The following is a description of a gene set: Human Gene Set: GOCC_COLLAGEN_TYPE_IV_TRIMER A collagen heterotrimer containing type IV alpha chains;2alpha2(IV) trimers are commonly observed, although more type IV alpha chains exist and may be present in type IV trimers; type IV collagen triple helices associate to form 3 dimensional nets within basement membranes. studied in species Homo sapiens, and this is the list of marker genes: COL4A1, COL4A2, COL4A3, COL4A5, COL4A6 (NCBI Gene Id 1288), COL4A4